Given this list of marker genes CD81, MAP3K1, HACD3, GRB2, PLCE1, SYK, FOS, MUC20, PRKCB, CDC42, DUSP16, STAT1, TIRAP, JAK1, HRAS, STAT3, JUN, AVPI1, RAB7B, IGHM, ARHGAP5, here is a description of the gene set: studied in species Mus musculus To identify biomarkers that discriminate the aggressive forms of prostate cancer, we performed gene expression profiling of prostate tumors using a genetically engineered mouse model that recapitulates the stages of human prostate cancer, namely Nkx3.1; Pten mutant mice. We observed a significant deregulation of the epidermal growth factor and mitogen-activated protein kinase (MAPK) signaling pathways, as well as their major downstream effectors--the activator protein-1 transcription factors c-Fos and c-Jun. Forced expression of c-Fos and c-Jun in prostate cancer cells promotes tumorigenicity and results in activation of extracellular signal-regulated kinase (Erk) MAPK signaling. In human prostate cancer, up-regulation of c-Fos and c-Jun proteins occurs in advanced disease and is correlated with Erk MAPK pathway activation, whereas high levels of c-Jun expression are associated with disease recurrence. Our analyses reveal a hitherto unappreciated role for AP-1 transcription factors in prostate cancer progression and identify c-Jun as a marker of high-risk prostate cancer. This study provides a striking example of how accurate mouse models can provide insights on molecular processes involved in progression and recurrence of human cancer. Genes up-regulated during prostate cancer progression in mice heterozygotic for both NKX3.1 and PTEN. from publication Ouyang X, Jessen WJ, Al-Ahmadie H, Serio AM, Lin Y, Shih WJ, Reuter VE, Scardino PT, Shen MM, Aronow BJ, Vickers AJ, Gerald WL, Abate-Shen C (PMID 18381418) Human Gene Set: OUYANG_PROSTATE_CANCER_PROGRESSION_UP